The following is a description of a gene set: studied in species Homo sapiens from publication El Kasmi KC, Holst J, Coffre M, Mielke L, de Pauw A, Lhocine N, Smith AM, Rutschman R, Kaushal D, Shen Y, Suda T, Donnelly RP, Myers MG Jr, Alexander W, Vignali DA, Watowich SS, Ernst M, Hilton DJ, Murray PJ (PMID 17114459) IL-10 or IL-6 stimulation of control 129xC57BL/6 murine bone marrow derived macrophages in the presence of LPS. We used microarrays to detail the global programme of gene expression changes in response to IL-6 or IL-10 stimulation in the presence of lipopolysaccharide. BMDMs were isolated from control, IL-6-/-, and IL-10-/- mice on a 129XBL/6 mixed background mice and differentiated in the presence of CSF-1 for 6-7 days. Cells were scraped and plated in 6 well plates at 2x10e6/well. Cells were washed with complete DMEM and rested for 1-2 hr before stimulation with combinations of IL-10 (10 ng/ml), IL-6 (2 ng/ml) or LPS (100 ng/ml) for 45 min or 180 mins. Complete biological replicates were performed. Genes down-regulated in bone marrow-derived macrophages with IL10 and 180 min stimulation of: LPS versus IL10 and LPS. Human Gene Set: GSE5589_LPS_VS_LPS_AND_IL10_STIM_IL10_KO_MACROPHAGE_180MIN_DN, and this is the list of marker genes: CDCP1, RABGGTA, MRPS23, ZRANB3, IL1RL1, MAP3K10, KCNK6, DIPK1A, PUS10, PDE8A, IQCF1, MTMR10, SFRP2, TDP2, TEX22, TGFBI, KCTD17, HRH2, ITGA5, MMP9, NAGPA (NCBI Gene Id 51172), MBOAT2, CRACDL, NUCB1, PABIR1, SPCS3, KCNH5, SGPP2, CD164, UBE2M, NTAQ1, TCEANC2, FEM1B, PLBD2, SLC37A4, OCSTAMP, NBDY, CRTC2, CCND3, RNF222, EHD1, IQCF5, VWA5A, AMFR, EIF2B2, UBE2V1, PEMT, ATXN7L3, TFPT, PANX1, SMAD2, ICAM4, PDIK1L, WFS1, ATIC, CNNM2 (NCBI Gene Id 54805), GDAP2, TMED4, VPS37B, CRLF2, DYNC2I2, GNPDA2, PLK1, RNF14, DEF6, RIMOC1, NEK9, MAD2L1BP, WIZ, KANSL1, SH3TC1, RPTOR, PFN1, B3GLCT, CAND2, PLCG1, ATP6AP2, RETSAT, DNAH12, GNG7, EFR3B, BORCS6, WLS, GTPBP6, TGFB1, RNF41, ARSB, BABAM2, NLRP3 (NCBI Gene Id 9558), FOLR1, NELFA (NCBI Gene Id 7469), CYLD, MAP3K9, SUPT16H, EDN1 (NCBI Gene Id 1906), PSD3, POFUT1, PFKFB4, NHERF2, NR5A2, FGF11, IL9R, SAMD5, AOC3 (amine oxidase copper containing 3), VEGFA, GFI1B, ZNF585A, MAP6, TNFRSF17, USP30, CASS4, A4GALT, PPM1A, DLGAP4, TIMP2, SP1, DOCK1, ZYX (zyxin), RHOBTB2, WASF2, RNF215, SNX15, C8orf82, KLF3, PEX26, ITGB7 (integrin subunit beta 7), GRAP, YWHAE (NCBI Gene Id 7531), OSM, IL3RA, DIP2C, ADORA2B, CA7, SBF1, MSR1, MBD2, CD40, CLDN10, RASGRP1, EID2, EIF3E, ASIC5, INSIG2, CYTH2, NECTIN4, PTPRA, RAB11A, TBL1X, STON2, ABCC1, JAG1, ADARB1, CHIC1 (cysteine rich hydrophobic domain 1), TBC1D17, FAM76B, SPRYD3, DNAJC30, QPCTL, CPNE2, APP, FOXRED2, SRPRA, CHST14 (carbohydrate sulfotransferase 14), SLC17A7, CLDND1, NES, SERTM1, HFE (NCBI Gene Id 3077), NFRKB, PHEX, ZNF334, ETS2, ZSWIM3, SQOR, MED17, KCNN4, TMEM74, ARHGAP15, MPV17L2, LRRC14, GALNT1, SIL1, LIMK1, CRTAP, SKI, ACSBG1, GATA2, SPR, CDK6, CDK10, TXNDC17, TM9SF4, LIME1, ARF4, SELL, BSG, P2RY1, PFKP, TLE5, RYR1